Given this list of marker genes FGFRL1, TRPM4, ALOXE3, PEX1, ITCH, COX7B, BRF1, LTBP1, SULT2B1 (NCBI Gene Id 6820), PNPLA1, CSTA, TRIO (trio Rho guanine nucleotide exchange factor), SPECC1L, PEX12, PTCH1, KMT2D, FBXO28, MED12, WAC, PIGL, KRT14, OTUD5, KRT9, TBX5, TRPS1, ADAMTS15, PORCN, BHLHA9, TSEN2, NBAS, DIS3L2, IFT122, ATP6V1B2, PEX26 (NCBI Gene Id 55670), MEGF8, NSDHL, POGLUT1, CYP4F22, RAPSN, AKT1, PPP2CA, TNFRSF1B, MTFMT, RPS23, ATR, FILIP1, KLHL24, PEX14, PEX10, ITGB4, CTC1, TRIM37, RAB11B, TSEN15, PTPRF, CFTR, POLR1A, GJA8, FGD1, IVNS1ABP, SDR9C7, SEPSECS, GJB2 (gap junction protein beta 2), KRT17, KDM6A, TNNT3, AQP5, AAGAB, TCF12, USF3, TELO2, APC, GLE1, GJA1, NECTIN1, ARID1B, VPS13B, NXN, TGDS, NAA20, KCNN3, TBCK, DSC2, KRT6B, SLURP1, TFAP2A (NCBI Gene Id 95131), TGM1, DSP, PEX13, GRHL2, CREBBP, MUSK, IGF1, CDSN, KRT5, KRT10, KDF1, CHST3, PEX19, H4C9 (NCBI Gene Id 8294), HPGD, BMPR1B, ATP6V1A, NOG, DST, PARN, EP300, MST1, EXTL3, ASXL2, SDHB (NCBI Gene Id 96200), ANKRD11, MEG3, TAF4, NECTIN4, GJB3, SMARCA2, COL14A1, MAP2K1, USB1, ALOX12B, PPP2R3C, PIEZO2, PACS1, DSG1, BCOR, PKP1, KRT1, COL17A1, PERP, YY1, ARL3, SLC18A3, SMOC1, LAMC2, DEPDC5, NAA10, NUP107, TSEN54, KAT6B, LMX1B, VPS51, SASH1, SMC3, MMP1, TMEM147, SPRED2, PTEN, SPRTN, VAC14, KRT2, NOP10 (NCBI Gene Id 55505), PLOD3, STS, NDUFB11, NPM1, MSL3 (MSL complex subunit 3), AUTS2, RTEL1, SHOC2, LIFR, ATP6V0A2, CPLX1, GJB6, UFC1, PEX16, ASXL3, KLK11 (kallikrein related peptidase 11), NUP88, C1R, EZH2, GPR101, CARD14, SMPD4, DKC1, RNU4ATAC, SMARCAD1, ZNF469, ADNP, TRAPPC11, AIP, H3-3A, FERMT1, CSNK2A1, GJA5, TUFT1 (NCBI Gene Id 7286), SLC39A13, DSE, PKDCC, KRT83, CHST14, DDX11, DPH2, CAST, KCNH1, MED25, CD96, WDR37 (NCBI Gene Id 22884), TINF2, PIGA, VPS33A, ATP2A2, CD4, SOX18, TBL1XR1, SDHD, DPYD, ASXL1, SET, GRIN1, MYH3, DHX30, SERPINA12, PEPD, XYLT1, LORICRIN, RPS6KA3, SMS (NCBI Gene Id 6735), RBM10, GNB2, PPP3CA, KATNB1, NEXMIF, PLEC, TP63, FOXP1, PIGS, PNPLA6, HCCS, TCF4, NUP188, AP1B1, MAP3K7, TERT, RHBDF2, PLAA, MAGEL2, MRAS, CTSB, MCOLN1, TPM2, CCBE1, EXT1, MTOR, FGF9, POMP, PDGFRB, KRT6C, PUF60, CDC42BPB, AFF3, PIK3CA, ESCO2, SLC25A12, DOCK6, TRIM8, SUFU, B3GLCT, RIPK4, B4GALT7, ADAMTSL1, HDAC4, CST6, NHP2, TAF6 (NCBI Gene Id 6878), WNT10A, SNAP29, UBR7 (NCBI Gene Id 55148), MEF2C, KLLN, SMC1A, SETBP1, HNRNPK, MAP2K2, FIG4, IFT43, KRT85, TERC, GLYCTK, AAAS, ZNF462, GDF5, RAD21, POLRMT, FBXO11, MTX2, POFUT1, U2AF2, TUBA1A, TNNI2, RNU4-2, CHD7, DLX4, STXBP1, COL7A1, COG6, RIN2, BMP4, SEC23B, AHDC1, IFT57, KRT6A, SEMA4D, SMC5, KRT16, LTBP4, KIF21A, PTCH2, SDHC, LSS, CLCN7, PLOD1, CERS3, PSENEN, DPAGT1, KDSR (3-ketodihydrosphingosine reductase), PPP1R13L, ENPP1, SLCO2A1, CTBP1, ABCA12 (ATP binding cassette subfamily A member 12), KDM4B, RTL1, MBTPS2, CILK1, MCTP2, TBX4, GMPPA, ACVRL1, NLRP1, CIB1, MAP1B, DPH1, COG1, FGFR3, CD28, BICD2, MYOD1, FLG, ZNF292, NIPAL4, CEP55, WRAP53, PDHA1, CDK19 (NCBI Gene Id 23097, cyclin dependent kinase 19), PEX5, GJB4, KRT74, GPR35, ALDH6A1, G6PC3, PEX6, RERE, PEX2, BRAF, RPL10, NIPBL, CEP57, KANK2, CKAP2L, JUP, CCNQ, UBE3B, SPTBN1, VPS33B, BRD4, LAMB3, HRAS, RIT1, CSGALNACT1, TASP1 (NCBI Gene Id 55617), EHMT1, EBF3, LZTR1, SRD5A3 (NCBI Gene Id 79644), CTCF, PRR12, LONP1, PGM2L1, KRAS, STAG1, SMAD2, DOK7, SERPINB7, FGFR2, TWIST1, ZC4H2, CTLA4, COX14, PEX11B, TOE1, CTSC, TGM5, FLNA, HDAC8, LBR, UBR1, LAMA3, LETM1, THOC2, NALCN, ZMYM2 (NCBI Gene Id 7750), CDK10, NSD2, NGLY1, PEX3, RSPO1, DLK1, TAT, TRPV3, SLC25A24 (NCBI Gene Id 92093), TYMS, JARID2, ROR2, ZFX, KCNK9, TSEN34, here is a description of the gene set: Abnormal skin morphology of the palm An abnormality of the skin of the palm, that is, the skin of the front of the hand. Human Gene Set: HP_ABNORMAL_SKIN_MORPHOLOGY_OF_THE_PALM studied in species Homo sapiens